The following is a description of a gene set: studied in species Mus musculus Mouse Gene Set: GOCC_MYELIN_SHEATH_ABAXONAL_REGION The region of the myelin sheath furthest from the axon., and this is the list of marker genes: Myoc, Prkcz, Exoc4, Llgl1, Cnp (NCBI Gene Id 12799), Sirt2, Itgb1, Scrib, Dlg1